The following is a description of a gene set: Up-regulated genes in medulloblastoma tumors from heterozygotic CXCR6 knockout mice compared to those from PTCH1 heterozygotic knockout mice. The sonic hedgehog (Shh) pathway is activated in approximately 30% of human medulloblastoma resulting in increased expression of downstream target genes. In about half of these cases, this has been shown to be a consequence of mutations in regulatory genes within the pathway, including Ptc1, Smo, and Sufu. However, for some tumors, no mutations have been detected in known pathway genes. This suggests that either mutations in other genes promote tumorigenesis or that epigenetic alterations increase pathway activity in these tumors. Here, we report that 3% to 4% of mice lacking either one or both functional copies of Cxcr6 develop medulloblastoma. Although CXCR6 is not known to be involved in Shh signaling, tumors derived from Cxcr6 mutant mice expressed Shh pathway target genes including Gli1, Gli2, Ptc2, and Sfrp1, indicating elevated pathway activity. Interestingly, the level of Ptc1 expression was decreased in tumor cells although two normal copies of Ptc1 were retained. This implies that reduced CXCR6 function leads to suppression of Ptc1 thereby increasing Smoothened function and promoting tumorigenesis. We used a direct transplant model to test the sensitivity of medulloblastoma arising in Cxcr6 mutant mice to a small-molecule inhibitor of Smoothened (HhAntag). We found that transplanted tumors were dramatically inhibited in mice treated for only 4 days with HhAntag. These findings suggest that HhAntag may be effective against tumors lacking mutations in known Shh pathway genes. species: Mus musculus Human Gene Set: SASAI_TARGETS_OF_CXCR6_AND_PTCH1_UP from publication Sasai K, Romer JT, Kimura H, Eberhart DE, Rice DS, Curran T (PMID 17413002), and this is the list of marker genes: SLC1A5, PPFIA4, PLCB4, GDPD3, XIST, VGF, TTR, L1CAM, IFI16, IFFO2, UQCR10, RNF112, OTX2, FOXD1